The following is a description of a gene set: Human Gene Set: GOBP_REGULATION_OF_BLOOD_PRESSURE Any process that modulates the force with which blood travels through the circulatory system. The process is controlled by a balance of processes that increase pressure and decrease pressure. species: Homo sapiens, and this is the list of marker genes: DRD5, CYP4A11, KLK1, ERAP1, DRD2, TACR3, ATP1A2, GNA13, ADAMTS16, SCNN1D, UTS2R, LEP, ERAP2, MKKS, ACSM3, GCH1, SPX, NPPA (NCBI Gene Id 90230), F2R, KCNJ8, NOS2, CYP4F12, EDNRA (endothelin receptor type A), PTGS1, MRGPRD, ANPEP, TNNI3, PTPRO, AVPR1A, RAMP2, GNB3 (G protein subunit beta 3), AGT, NPFF, POSTN, SGK1, SOD2, NMU, NCALD, SLC2A5, FFAR3, NOS1, ATP1A1, GUCA2B, FSHR, TNF, GRIP2, OXTR, GCGR, EMILIN2, AGTR1, KCNK3, SOD1, COMT, ADRB2, P2RX2, QRFP, GPR37L1, P2RX4, SCNN1A, BBS4, LNPEP, SCPEP1, ECE1, NPR3, AVPR1B, APLN, ABAT, VEGFC, RPS6KA2, ADRB3, CYP4F2, P2RX1, TBXA2R, CORIN, GJA5, ADRB1, PTPN1, MIR17, MAS1, EXT2, TACR1, CTSZ, ATP6AP2, ADM2, RARRES2, POMC, REN, CMA1, ABCC9, ACE (NCBI Gene Id 654142), MME, OR51E2, EDN1, TAC4, ATP2B1, DDAH1, MECP2, AVP, CHGA, AR, PDGFB, PRCP (NCBI Gene Id 5547), UTS2, IER3, EDN3, KCNQ1, AGTRAP, ADH5, TPM1, GAS6, EMP2, COL1A2, BRS3, ID2, MANF, EMILIN1, AVPR2, PCSK5, NR2F2, CTSG, MC3R, NPR2, KL, RHOA, EXT1, SUCNR1, TAC1, CPA3, NOS3, CYP11B2, WNK1, UMOD, OXT, EDN2, NOX1, GLP1R, RNLS, CARTPT, WNK4, NPPB, MYH6, STK39, MIR199A1, PPARA, ACE2, SCNN1B (NCBI Gene Id 6338), RASL10B, CORO2B, NAV2, HBB, KCNK6, ARHGAP42, SLC4A5, NTSR1, F2RL1, DLL1, BMPR2, PTGS2, KLK2, CRH, GNA12, PLCB3, ASIC2, BDKRB1, HSD11B2, ADIPOQ, SERPINF2, NPY1R, SMAD3, NDST2, EDNRB, TAC3, CALCA, RENBP, GNA11, PREP, NPR1, GUCY1A1, TTR, KLK3, ADM, NPY, ADM5, ACTA2, ADRA2B, SNX5, CYBA, PPARG, ACVRL1, ENG, ADORA1, DRD3, CYP11B1, GSK3A, UTS2B, LRP5, UCN, AGTR2, MIR27B, SCNN1G, ENPEP, ADRA1A